The following is a description of a gene set: This event has been computationally inferred from an event that has been demonstrated in another species.<p>The inference is based on the homology mapping from PANTHER. Briefly, reactions for which all involved PhysicalEntities (in input, output and catalyst) have a mapped orthologue/paralogue (for complexes at least 75% of components must have a mapping) are inferred to the other species. electronically inferred by orthology from the curated human pathway studied in species Mus musculus part of: Signaling by MET Reactome Pathway: Negative regulation of MET activity, and this is the list of marker genes: Grb2, Sh3gl3, Ubb, Stam, Ptpn1, Rps27a, Cbl, Hgf, Ptpn2